The following is a description of a gene set: Neutrophils are known to be stimulated by different periodontal bacteria to produce reactive oxygen species and cytokines. It is inportant to investigate the gene changes made by bacteria of importance, of which, for periodontal disease, fusobaterium nucleatum is one. we used microarrays to investigate gene experssion changes in peripheral blood neutrophils werwhich e stimulated with or with out Fusobacterium Nucleatum (10953). studied in species Homo sapiens from publication Wright HJ, Chapple IL, Matthews JB, Cooper PR (PMID 20663022) Genes up-regulated in comparison of contols neutrophils versus those infected with a bacterium (F. nucleatum). Human Gene Set: GSE20151_CTRL_VS_FUSOBACT_NUCLEATUM_NEUTROPHIL_UP, and this is the list of marker genes: UTP20, FRMPD1, KPNA6, DLEC1, HDGF, GPR22, FBXO41, SLC43A3, TRPM8, CCDC40 (coiled-coil domain 40 molecular ruler complex subunit), FRS2, PHF1, BIN3 (NCBI Gene Id 55909), PLK1, MAGI1, SST, EPM2A, SLC39A4, GSTZ1, LOX, SMIM14, PTPN14 (NCBI Gene Id 5784), ENSG00000289047, SPRY2, ADAR, ZNF202, TTI2, KLHL4, PDK2, ATP1A1, COL9A1, PSORS1C2, SMCP, UCHL3, CADM1, GRB7, DNAH17 (NCBI Gene Id 8632), MYO7A, PCBD1, KRT23, CDC25A, RRP7A (NCBI Gene Id 27341), MBD3 (NCBI Gene Id 8931), SRF, EPHX1, HMGCL, CPLANE1, OR3A2, ZNHIT2 (zinc finger HIT-type containing 2), UPK1A, NPBWR2, IFIH1, ASH1L, MAP7, MSX2, FGR, NMI, FGF17, PBK, SLC15A3, APOL3, KCNA3, GCH1, TRAF4, SETD5, HS3ST2, AKR1A1, SMAD3, PALLD, TRAF1 (NCBI Gene Id 7185), MAP3K9, RABGEF1, LILRB1, HBP1, SFSWAP, ARAP1, ETNPPL, PTCD2, FHOD1, LOXL2, TXN2, APEX2, WNT1, SSBP3, USE1, GSTA3, PWAR5, CCR3, CKM, TFAP2B, FCER2, STAT1, LY6E, GPR39, TSNAXIP1 (NCBI Gene Id 55815), TRIO (trio Rho guanine nucleotide exchange factor), LUZP2, IFIT3, CNTNAP1, SASH3, MAP3K11, SZT2, MCUR1, RRAS, RUBCNL, MOXD1, SPDEF, PARN, MBD1, PAQR4, ECE1, ESRRA, MYH15 (NCBI Gene Id 22989), INSM1, GJA9, ZC3H12A, C11orf16, CAMKK2, MDC1, CCDC88A, ZFHX3, CFAP410, DSC3, MOCS3, GINS3, BTNL8, TUSC2, TBC1D2B, RHBDF2, CALML5, SPINK4, MGMT, TACR3, MYL11, SPATA1, ENTPD1-AS1, COL10A1, AGT, KLK11, ADRA2C, CPZ, MLST8, PRR5L, SLC28A2, SLC22A1 (NCBI Gene Id 6580), IRF7, TUBG2, SERPINC1, SEZ6L, SQOR (sulfide quinone oxidoreductase), ZMYM6, MANF, NPHS1, ZNF749, ZDHHC18, HGFAC, NCAM1, MKRN7P, PSORS1C1, CCSER2, FAM86B1, ZNF335, TNP2, TSSC4, FAM120C, CUL7, SERPINB13, ZYX, SLC6A4, VASH1, DGKI, TSPAN14, CCDC57, UCN, MID1IP1, VIL1, TCL6, P4HTM, BCAT2, LDB3, BAZ1A, IL1RAPL2, PEX5L, KHDRBS3, MRPL34, PHKG1, SURF2, DARS2, ATG13, ALCAM, PI15, GIPR, SLC6A8, DENND1C, AP2B1, CAMK4, C19orf73, IGFALS